Given this list of marker genes MPC2, WNT9B, NR4A3, COL15A1, RCOR3, BRAP, TREML2 (triggering receptor expressed on myeloid cells like 2), NAA15, DCTN5, N4BP2, ZNF527, CCDC47 (coiled-coil domain containing 47), IPO9 (NCBI Gene Id 55705), CREB3L3, SPPL3, EIF2AK4 (NCBI Gene Id 440275), NSD1, SMAD4, PSEN1, OLR1, RBMS2, CX3CL1 (C-X3-C motif chemokine ligand 1), SH3BGRL2, AKAP6, POU2F3, HIVEP1 (NCBI Gene Id 3096), GALNT6, FAM149A, NAT8L, C2orf72, TBC1D5, PLGLB1, TMTC2, SULT1C4, PTPN18, CIAO2A, PLPP3, VMAC, EPHA3, ATXN2L, POLR2F, KMT2C, STX3, WBP1L, NFIA, DSCAML1, DOCK3, SOX14, PDAP1, SCN8A, TMEM106A, ATP9B, BDP1, DSCAM, PLGLB2, SYNGR3, MKRN1, SNPH, FEM1B, WDR6, SCAMP1, KCNC4, ASPN, ZNF140, DYRK1A, STMP1, GRIN1, SEC23A, ADGRF5, PFN2 (NCBI Gene Id 85837), CEP72, LEPR, ST13, PKDCC, SMAD3, CTIF, CNOT2, CNTF, HSPB7, TLL1, ZRANB1, COG6, STN1, here is a description of the gene set: Human Gene Set: MIR3120_5P studied in species Homo sapiens Genes predicted to be targets of miRBase v22 microRNA hsa-miR-3120-5p in miRDB v6.0 with MirTarget v4 prediction scores > 80 (high confidence targets). from publication Chen Y, Wang X (PMID 31504780)